The following is a description of a gene set: The chemical reactions and pathways involving monosaccharides, the simplest carbohydrates. They are polyhydric alcohols containing either an aldehyde or a keto group and between three to ten or more carbon atoms. They form the constitutional repeating units of oligo- and polysaccharides. species: Homo sapiens Human Gene Set: GOBP_MONOSACCHARIDE_METABOLIC_PROCESS, and this is the list of marker genes: PFKFB2, FAM3A, PDHB, PMM2, IRS2, ADCY10, GLB1L2, GSTO2, IRS1 (insulin receptor substrate 1), G6PC2, FBP1, PGK1, GCG, SIRT7, NFE2L1, GHRL, PGM2L1, MIR107, LIPA, KAT2A, LEP, INSR, MIR103A1, SORD, PDHA2, C1QTNF1, XYLB, PPP1R3E, CHST15, HK3, INPPL1, INS, EP300, PRKAG3, PPARA, PMAIP1, PGAM2 (NCBI Gene Id 5224), ADIPOR1, FUT6, BAD, WDR5, ZFP92, ACADM, PPP4R3A, GDPGP1, SESN2, AKT2, KCNJ11, GLYCTK, PMM1, OTOGL (NCBI Gene Id 651200), LRP5, PDK4, PTPN2, ERRFI1, GLB1L3, PGP, MST1, WDTC1 (NCBI Gene Id 23038), MAN2A2, RPIA, PRKAA1, GALE, CLK2, GMPPB, FUT2, ATP1A2, SLC23A1, PRKN, HECTD4, NR3C1, H6PD, GPLD1, ACTN3, PHKA1, SLC25A13, DGAT2, SLC25A11, CLSTN3, FKRP, ERO1A, TFAP2B, APOD, NR0B1, GSK3A, FUCA1, FUCA2, PGD, PDK1, IGFBP4, USP7, FOXK1 (NCBI Gene Id 650798), TFF3, IGF2, GPD2, PDX1, MTCL2, KAT2B (lysine acetyltransferase 2B), ACACB, BRS3, SIK1, TNF, GALT, PPP1CA (NCBI Gene Id 5499), NNMT, BCKDK (branched chain keto acid dehydrogenase kinase), PFKFB3 (NCBI Gene Id 5209), GAPDHS, MDH2, B4GALT1 (beta-1,4-galactosyltransferase 1), ZNF692, PRKAG1, PDK3, OGT, SERPINA12, FUT7, SLC2A3, PRKACA, SORBS1, SLC23A2, ENO3, FGGY, BOLA3 (bolA family member 3), TIGAR (NCBI Gene Id 57199), FUOM, LDHA (NCBI Gene Id 3939), PHKG2, PPARGC1A, KBTBD2, SDHAF3, RORA, DDB1, ALDOC, HKDC1 (NCBI Gene Id 80201), HK2 (hexokinase 2), NPY1R, OAS1, TKFC, SLC35B4, BRAT1, NLN, PPP4R3B, PER2, GSTO1, GALK2, FUT1, FOXK2, NUDT5, PCK2, POFUT1, ONECUT1, CHST1, FUT4, C1QTNF3, PGAM1, HK1, SELENOS, OMA1, SIRT6, PFKL, RANBP2, SELENON, GALK1, PKM, FBP2, PFKM, GLB1L, FPGT, GPI, CRTC2, FUT10, PGM2, SLC25A10, SLC37A4, FABP5 (fatty acid binding protein 5), LCMT1, AKR1B1, ENO1, FUT5, ENO2, GNB3, SLC35A2, FUT9, ADPGK (ADP dependent glucokinase), DCXR, DYRK2, TKTL1, B3GLCT, MAN2C1, HSD17B14, DLAT, SLC2A1, POFUT2, MAN2B1, RORC, IGFBP3, PCK1, GAL3ST3, PPARD, GOT1, TP53, AKT1, LEPR, GPD1, FOXO1, SLC45A3, FBN1, ZMPSTE24, MIR210, PIK3CA, G6PD, FUT8, G6PC1, ARPP19, GNMT, ATF4, ALDOB, KCNQ1, UXS1, G6PC3, SLC39A14, GCLC, SDS, RBP4, PFKFB1, PTH, PFKFB4, TPI1, PDHA1, MLYCD, OTOG, DGKQ, ADIPOQ, RBKS, DHDH, NCOA2, SERP1, SIRT1, IGF1, ATF3, PFKP, PGM1, PPP1R3B, MAN2B2, BCL2L13, PDK2, MPI, ALDOA, CPT1A (NCBI Gene Id 1374), GALM, HMGB1, PPP1R3G, KHK, GAA, C1QTNF12, USF1, PGK2, GLB1, GAPDH, EPM2AIP1, CRY1, TCF7L2, PC, GCK, MAN2A1, PRKAG2 (protein kinase AMP-activated non-catalytic subunit gamma 2), ERFE, MAPK14